The following is a description of a gene set: studied in species Homo sapiens Human Gene Set: MIR3922_3P from publication Chen Y, Wang X (PMID 31504780) Genes predicted to be targets of miRBase v22 microRNA hsa-miR-3922-3p in miRDB v6.0 with MirTarget v4 prediction scores > 80 (high confidence targets)., and this is the list of marker genes: MYLK2, CAMK1G, CHTF8, GNAZ, ITGA5 (NCBI Gene Id 3678), ATXN1, ASB8, NIPAL4, VASH1, ARHGEF12, KLF7, AIMP2, AKR1C3, ARMC9, PEA15, RABGAP1, CNOT2, PPP1R12A, STARD7, DCX, CRADD, NUFIP2, FHDC1, MTCL2, TRMT61A, TBC1D5, AKAP13, YPEL1 (yippee like 1), SYTL5, P2RY10, SYT17, PTPN7, TMEM230, RAC2, TRPM8, ERICH2, GALNT14, RAD52, LUZP1, ERBIN, LRRC8A, SOS2, TRABD2B, CMTM6, ZNF397 (NCBI Gene Id 84307), INO80D, FAT4, SERPINA11, NT5DC3, VWA5B1, MED9, PKM, TTC39C, GREM1, KCNJ2, RNASE13, IFT88, CADM1, PATE2, SUV39H1, ZNF500, SLC12A6, ZBTB7C, ARB2A, COX11, SMIM14, ABCB10, MTF1, AP4B1, GTPBP2, PIGH, CD247, SP4, MMP1, ETS1, KSR2, LMX1A, URM1, ADNP, GMCL1, RSBN1L, ARHGDIB, CST3, SETDB2, ZBTB37, ADGRL3, CLOCK, CNOT6 (NCBI Gene Id 60404), BMF, KDM2A, NFAM1, LIMD1, ZYG11B, ERBB4, GRAMD1B, ZNF618